Given this list of marker genes TP53INP2, FGF11, ENPP3, RABGAP1, FAM131A, CD40LG, OSBP2, CISH, NDRG1, CERCAM, CBS, PIK3IP1, A4GALT, FBXO6, NT5C3B, TNFRSF4, TGM2, DAB2, TLE3, PLVAP, MAP1A, P2RX4, PFKFB4, DDIT4, CTNS, SH3BP4, P4HA2, NCS1, TJP2, PLXNA3, CPXM1, SLC2A10, DCPS, ST3GAL4, HBZ, IL4R, MTHFD1, TULP3, SLC6A9, SYNE3, TMEFF2, TMEM116, HSPA6, SOS1, MOSPD3, MIIP, RAP1GAP, PCSK9, DHRS3, CYSTM1, SAMSN1, F2RL1, HILPDA, PIM1, RASGEF1A, RHAG (NCBI Gene Id 6005), SEMA6C, IGFBP4, IL18RAP, UPK1A, SMAP2, GGT5, MEX3D, HYCC2 (NCBI Gene Id 285172), BATF3, BBX, KRBA1, PRPS1, GBP4, NAAA, ITGA2, MUC1, TARP, DAPK1, TGFBR1, GPAT3, AMACR, SLC9A7, CTSH, CD1A, ENC1, CIART, TRIM46, XIRP1, DUSP5, CDHR1, TNFAIP8L3, DPYSL4, SNTA1, ADGRG5, FNDC3B, KISS1R, UBAC1, ADM, IL4I1, CDKN1C, GYPB, RHEBL1, NAALADL1, SLC25A4, HSPA2, FCER2, SLC25A37, GATA2, TRIB3, MYO10, PLEKHA4, TRIM58, STK17B (serine/threonine kinase 17b), CALB2, ARL4A, IGFBP5, SPAG4, CTXN1, CTSZ, VASN, CCDC102A, IL3RA, NIBAN2, CFH, POU2F1 (NCBI Gene Id 7823), SCHIP1, NOD1, LTB, CST7, PHLDA1, ST3GAL5, here is a description of the gene set: The level of transcription factor activity critically regulates cell fate decisions, such as hematopoietic stem cell (HSC) self-renewal and differentiation. We introduced STAT5A transcriptional activity into human HSCs/progenitor cells in a dose-dependent manner by overexpression of a tamoxifen-inducible STAT5A(1*6)-estrogen receptor fusion protein. Induction of STAT5A activity in CD34(+) cells resulted in impaired myelopoiesis and induction of erythropoiesis, which was most pronounced at the highest STAT5A transactivation levels. In contrast, intermediate STAT5A activity levels resulted in the most pronounced proliferative advantage of CD34(+) cells. This coincided with increased cobblestone area-forming cell and long-term-culture-initiating cell frequencies, which were predominantly elevated at intermediate STAT5A activity levels but not at high STAT5A levels. Self-renewal of progenitors was addressed by serial replating of CFU, and only progenitors containing intermediate STAT5A activity levels contained self-renewal capacity. By extensive gene expression profiling we could identify gene expression patterns of STAT5 target genes that predominantly associated with a self-renewal and long-term expansion phenotype versus those that identified a predominant differentiation phenotype. Human Gene Set: WIERENGA_STAT5A_TARGETS_GROUP1 studied in species Homo sapiens from publication Wierenga AT, Vellenga E, Schuringa JJ (PMID 18779318) Genes up-regulated to their maximal levels in CD34+ cells by intermediate activity levels of STAT5A; predominant long-term growth and self-renewal phenotype.